Given this list of marker genes ZNF76, CAPRIN1, GLA, PDE6G, PDE6B, DRAP1 (NCBI Gene Id 119810), MYH7, ITGB3BP, TTF1, NMI, WAS, PMS2P11, MADD, LYST, ARHGAP4, PTGES3 (prostaglandin E synthase 3), GRM4, DRG2, TAF11 (TATA-box binding protein associated factor 11), INPP5D, MPV17, SPN, PIK3CG, VPS72, RABGGTA, DGCR6, TEC, SMARCD1, HNRNPL, ARHGEF1, NSMAF, VAV1, TRIP13, HMGA2, SMARCD2 (SWI/SNF related, matrix associated, actin dependent regulator of chromatin, subfamily d, member 2), GPSM3, AIP, RGS19, ZNF134, COX10, CLCN7, RENBP, FANCC, SLC29A2, DDX18, SUPT4H1, CCR9, here is a description of the gene set: Human Gene Set: GCM_VAV1 Neighborhood of VAV1 Neighborhood of VAV1 vav 1 oncogene in the GCM expression compendium species: Homo sapiens